The following is a description of a gene set: part of: Meiosis This event has been computationally inferred from an event that has been demonstrated in another species.<p>The inference is based on the homology mapping from PANTHER. Briefly, reactions for which all involved PhysicalEntities (in input, output and catalyst) have a mapped orthologue/paralogue (for complexes at least 75% of components must have a mapping) are inferred to the other species. Reactome Pathway: Meiotic recombination studied in species Mus musculus electronically inferred by orthology from the curated human pathway, and this is the list of marker genes: Dmc1, Firrm, Fignl1